The following is a description of a gene set: studied in species Mus musculus Mouse Gene Set: GOBP_MYOBLAST_MIGRATION The orderly movement of a myoblast from one site to another, often during the development of a multicellular organism. A myoblast is a cell type that, by fusion with other myoblasts, gives rise to the myotubes that eventually develop into skeletal muscle fibers., and this is the list of marker genes: Thbs4, Megf10, Smo, Akirin1, Rock1, Net1, Itgb1bp1 (NCBI Gene Id 16413), Pax3, Six4, Bin3, Mstn, Six1, Plekho1, Naca, Anxa1